Given this list of marker genes RYBP, DEGS1, GRIPAP1, SLC20A1, NT5DC3, MINDY2, GARRE1, M6PR, OSBPL8, REST, MREG, MAFK, CRISP3, SLC25A25, DENND4A, MED15, KPNA6, VPREB3 (V-set pre-B cell surrogate light chain 3), C21orf91, NAB1, POLR3F, HLA-DOB, CAMKK1, TUFT1, TNFRSF12A, STK40, ADM, SLC1A5, RBBP8, ZFAND2A, DPP7, BACH1, EPC1 (NCBI Gene Id 80314), GP5, SFN, IRF2BP2, EXOSC1, TRIM3, GRAMD2B, SHQ1, LIMK2, SH3BP5, CDC16, TPD52, GNL2, BEND3, DNAJB5, ABHD16A, CNOT6L, ADGRL2, S1PR3, TECPR1, TEC, AFMID, SLC35B3, CD74, DUS4L, TRMT6, GPR137B, NT5C3A, ZBTB10, PALS2, APOE, BDP1, DNAJC16, MED7 (NCBI Gene Id 9443), MAP3K8, PLGRKT, SUN2, MYO1E, SCPEP1, ZNF841, MAT2A, MAPK8, S1PR1, GNS, SRSF11, LDLRAD3, SLC66A2, RRAGC, BRWD1, ZHX2, TCF12, IRF4, LGALSL, WTAP, SLC7A1, SRF, CLIC4, ACER3, FBXO31, MFSD1, CEP170B, MNT, LCORL, CYRIA, NFATC1, RBM47, ADGRE5, TXNDC16, ADIPOR2, IRF8, RETREG1, GIMAP4, MYBPC2, TSC22D1, IFRD1, AGPAT5, SLC39A6, DOCK10, CCDC115, PDE7B (phosphodiesterase 7B), ZNF655, CD274, MZT1, GTDC1, SLC44A2 (solute carrier family 44 member 2 (CTL2 blood group)), TMED5, TAF1A (NCBI Gene Id 9015), DUSP10, CEBPZ, ITPRIP, STAMBPL1, ATP2B1, PDCD1LG2, TF, CSTB, SPP1, ZNHIT6, TULP4, RRH, SLC17A5, B4GALT5, TOM1, ATXN2, EPB41L2, JCAD, ZNF622, DHX33, HNRNPR, NBEAL1, BTG1, RBM34, TNFRSF21, SLC9A8 (NCBI Gene Id 23315), FOXJ3, CXCR5, SLC7A5, TBCEL (tubulin folding cofactor E like), DCAF5, UBP1, PIP4P1, BNIPL, ZBED5, PDE7A, ERO1B, ZBTB20, STAR, PIK3IP1, RIPK2, TEF, NR1D2, RERE (arginine-glutamic acid dipeptide repeats), AFF1, GCLC, KMT5A, MSANTD2 (NCBI Gene Id 79684), FYN, CAMSAP1, SIDT2, TAOK1, SATB1, TXNRD3, MAU2, PNPLA7, SSPN, MLXIP, ZBTB2, PDZD8, OPA3, POU2AF1, DUSP3, PLK3, CDC42BPG, NSD3, EXOC8, REV3L, BIRC3, CUL4A, VEGFA, AHCTF1, PURA, IL17RA, DDX50, LTB, UBL3, SERPINB1, FAM167A, CNOT4 (CCR4-NOT transcription complex subunit 4), TNFAIP2, here is a description of the gene set: studied in species Homo sapiens from publication Ghoreschi K, Laurence A, Yang XP, Tato CM, McGeachy MJ, Konkel JE, Ramos HL, Wei L, Davidson TS, Bouladoux N, Grainger JR, Chen Q, Kanno Y, Watford WT, Sun HW, Eberl G, Shevach EM, Belkaid Y, Cua DJ, Chen W, O'Shea JJ (PMID 20962846) Genes down-regulated in CD4 T cells treated with IL1B and IL6 versus those also treated with IL-23. CD4+ T cells that selectively produce interleukin (IL)-17, are critical for host defense and autoimmunity1-4. Crucial for T helper17 (Th17) cells in vivo5,6, IL-23 has been thought to be incapable of driving initial differentiation. Rather, IL-6 and transforming growth factor (TGF)-β1 have been argued to be the factors responsible for initiating specification7-10. Herein, we show that Th17 differentiation occurs in the absence of TGF-β signaling. Neither IL-6 nor IL-23 alone efficiently generated Th17 cells; however, these cytokines in combination with IL-1β effectively induced IL-17 production in naïve precursors, independently of TGF-β. Epigenetic modification of the Il17a/Il17f and Rorc promoters proceeded without TGF-β1, allowing the generation of cells that co-expressed Rorγt and T-bet. T-bet+Rorγt+ Th17 cells are generated in vivo during experimental allergic encephalomyelitis (EAE), and adoptively transferred Th17 cells generated with IL-23 in the absence of TGF-β1 were more pathogenic in this experimental disease. These data suggest a new model for Th17 differentiation. Consistent with genetic data linking the IL23R with autoimmunity, our findings re-emphasize the role of IL-23 and therefore have important implications for the development of new therapies. Human Gene Set: GSE23505_IL6_IL1_VS_IL6_IL1_IL23_TREATED_CD4_TCELL_DN